The following is a description of a gene set: studied in species Homo sapiens The gene expression program underlying the specification of human cell types is of fundamental interest. The study authors generated human cell atlases of gene expression and chromatin accessibility in fetal tissues. For gene expression, the study authors applied three-level combinatorial indexing to >110 samples representing 15 organs, ultimately profiling ~4 million single cells. The study authors leveraged the literature and other atlases to identify and annotate hundreds of cell types and subtypes, both within and across tissues. Our analyses focused on organ-specific specializations of broadly distributed cell types (such as blood, endothelial, and epithelial), sites of fetal erythropoiesis (which notably included the adrenal gland), and integration with mouse developmental atlases (such as conserved specification of blood cells). These data represent a rich resource for the exploration of in vivo human gene expression in diverse tissues and cell types. Marker genes curated from the annotated cluster as represented in the Descartes Human Gene Expression During Development database. from publication Cao J, O'Day DR, Pliner HA, Kingsley PD, Deng M, Daza RM, Zager MA, Aldinger KA, Blecher-Gonen R, Zhang F, Spielmann M, Palis J, Doherty D, Steemers FJ, Glass IA, Trapnell C, Shendure J (PMID 33184181) Human Gene Set: DESCARTES_FETAL_MUSCLE_SATELLITE_CELLS, and this is the list of marker genes: RN7SL37P, SOX9, NTN4, MT1M, GDPD4, CCDC162P, LINC01121, CLCN5, CALN1, ADAMTS16-DT, GRIA4, EDN3, MYEOV, LINC02367 (long intergenic non-protein coding RNA 2367), LMF1-AS1, MAGEC3, CCER2, OPRD1, SPATA13, PITX3, LRRTM3, SPATS2L, BNC1, MEGF10, LINC01111, LINC01994, GSG1L, POU4F1, MYF5, CNGA3, CADM2, ANKRD18B, FGFR4, ADGRA1, ERFE, USP44, C1QTNF3, NXPH2, RPS3AP25, TSPAN12, LINC01224 (NCBI Gene Id 104472717), CHRDL2, LINC02821, PAX7, NPY, TACR3, MAPK15, AMH (anti-Mullerian hormone), RNU6-1327P, CELA2B, GALNT14, OTOF, RGR, GCK, RNY4P34, KRT40, NEU4, ENPP7P10